Given this list of marker genes Cpox, Alas1, Uros, Ppox, Alad, Urod, Cox10 (heme A:farnesyltransferase cytochrome c oxidase assembly factor 10), Cox15, Flvcr1, Fech, Alb, Alas2, Hmbs, here is a description of the gene set: Mouse Gene Set: REACTOME_HEME_BIOSYNTHESIS Heme biosynthesis species: Mus musculus